Given this list of marker genes PPA1, IFI27, IL4I1, PSME2, IRF7, WARS1, CXCL10, IFI6, PARP14, ISG15, IDO1, TNFSF13B, NT5C3A, MT2A, PSMB9, VAMP5, IFI35, GBP1, OAS2 (NCBI Gene Id 4939), GBP4, APOBEC3A, RSAD2, MX1, ANKRD22, GBP2, SERPING1, OAS1, CCL2, SAMD9L, TAP1, STAT1, IFITM3, IFIT2, IFIT1, IFIT3, GBP5, IFITM1, CCL8, IFI44L, EPSTI1, UBE2L6, CXCL11, TNFSF10, CALHM6, MX2, LAP3, ISG20, PLAAT4, CXCL9, LY6E, here is a description of the gene set: Human Gene Set: GAVISH_3CA_METAPROGRAM_MACROPHAGES_INTERFERON species: Homo sapiens from publication Gavish A, Tyler M, Greenwald AC, Hoefflin R, Simkin D, Tschernichovsky R, Galili Darnell N, Somech E, Barbolin C, Antman T, Kovarsky D, Barrett T, Gonzalez Castro LN, Halder D, Chanoch-Myers R, Laffy J, Mints M, Wider A, Tal R, Spitzer A, Hara T, Raitses-Gurevich M, Stossel C, Golan T, Tirosh A, Suvà ML, Puram SV, Tirosh I (PMID 37258682) Genes upregulated in subsets of cells of a given type within various tumors In this study, an extensive analysis was conducted to define meta-programs (MPs) capturing intra-tumor heterogeneity across a spectrum of tumor types. The approach utilized non-negative matrix factorization (NMF) to analyze each cell type separately within individual tumor samples. This involved the analysis of malignant cells, macrophages, fibroblasts, endothelial cells, epithelial cells, T-cells, and B-cells. NMF was executed with varying parameter values (K=4, 5, 6, 7, 8, 9), thereby generating 39 programs for each cell type per sample. Each NMF program was summarized by the top genes based on NMF coefficients.\nRobust MPs were then delineated for each cell type using a set of stringent criteria, including recurrence within the same tumor, similarity to programs in other tumors, and non-redundancy within a tumor. Subsequently, these robust NMF programs were clustered (per cell type) based on Jaccard similarity, leading to the identification of MPs associated with each cell type.\nTo enhance the quality of the MPs, a refinement steps were undertaken, involving the removal of MPs suspected of reflecting low-quality data (with an overrepresentation of ribosomal proteins or mitochondrial-encoded genes), single-study inclusion, or similarity to miss-annotated cell types.